Given this list of marker genes TUBB3, ERCC8, CFAP43, SPIN4, ERCC6, SCN4A (sodium voltage-gated channel alpha subunit 4), here is a description of the gene set: A form of hydrocephalus characterized by enlarged cerebral ventricles and normal cerebrospinal fluid (CSF) pressure upon lumbar puncture. studied in species Homo sapiens Normal pressure hydrocephalus Human Gene Set: HP_NORMAL_PRESSURE_HYDROCEPHALUS